The following is a description of a gene set: Quiescent and dividing hemopoietic stem cells (HSC) display marked differences in their ability to move between the peripheral circulation and the bone marrow. Specifically, long-term engraftment potential predominantly resides in the quiescent HSC subfraction, and G-CSF mobilization results in the preferential accumulation of quiescent HSC in the periphery. In contrast, stem cells from chronic myeloid leukemia (CML) patients display a constitutive presence in the circulation. To understand the molecular basis for this, we have used microarray technology to analyze the transcriptional differences between dividing and quiescent, normal, and CML-derived CD34+ cells. Our data show a remarkable transcriptional similarity between normal and CML dividing cells, suggesting that the effects of BCR-ABL on the CD34+ cell transcriptome are more limited than previously thought. In addition, we show that quiescent CML cells are more similar to their dividing counterparts than quiescent normal cells are to theirs. We also show these transcriptional differences to be reflected in the altered proliferative activity of normal and CML CD34+ cells. Of the most interest is that the major class of genes that is more abundant in the quiescent cells compared with the dividing cells encodes members of the chemokine family. We propose a role for chemokines expressed by quiescent HSC in the orchestration of CD34+ cell mobilization. Disclosure of potential conflicts of interest is found at the end of this article. from publication Graham SM, Vass JK, Holyoake TL, Graham GJ (PMID 17717066) Human Gene Set: GRAHAM_CML_DIVIDING_VS_NORMAL_DIVIDING_UP Genes up-regulated in dividing CD34+ cells isolated from peripheral blood of CML (chronic myeloid leukemia) patients compared to the dividing cells from normal donors. species: Homo sapiens, and this is the list of marker genes: RHAG, CYP1B1, H2BC12, TPSAB1, CSTA, H1-2, PROS1, CLC, RNASE2 (ribonuclease A family member 2), DLGAP5, PF4, PIEZO2, XIST, PPBP